Given this list of marker genes NEBL, ADD3, ZBTB20, QKI, AMOTL2, C3orf38, DGKH, KIAA0232, YIPF6, TCF20, SUGP2, ZBTB10, NR2C2, KCTD1, RAB3B, VXN, SGMS1, TYW1B, GRM5, FBXL4, ARL10, PITPNB, ZFHX2, MEGF11, ZNF281, HS1BP3, ZNF570, ARID1B, YWHAB, LMNA, CNTN4, SEC14L1, ZFP36L1, APOOL, TSHZ1, LPP, VPS36, NRXN1, RARRES1, USP49, RBFOX1, MME, SHISA9, ATRN, MINAR1, GLUL, SSH2, MED13L, INO80D, PDS5A, F2R, IVD, BICD2, FCHO2, ZNF470, ARID4A, HBS1L, SMIM9, ERAP1, ZNF704, STEAP2, MEPE, KIF1B, MEF2A, SLC13A1, GTF2A1, PIGK, PIGBOS1, PBX1, MBNL1, ZMAT2, CELF1, CDH12, UNC5D, MAPRE1, GFRA2, LDB3, NRG2, SOS2, MED12L, SCN8A, FRYL, CADM2, CREB5, G3BP1, SBK1, CTBP2, CKAP4, DDHD1, ACVR1C, PHIP, NRXN3, MAST4, MRPL44, F13A1, SGCD, GK5, JADE1, CHRNA3, DUSP10, LAMA4, INHBC, DSTYK, TENT4B, WNK3, GNRHR, OTUD6B, USP13, KLHL24, PCDH7, KLHL31, FUT9, AHDC1, CTH, DNMT3A, ZFP36L2, PTP4A1, POLR3E, MTF1, VPS26A, PKHD1, C1RL, MDM4, SMAD4, IKZF2, TENT5A, CFAP68, TENM1, C2orf88, YIPF5, TNRC6C, RUNX1, FNDC5, NFIB, CAMTA1, RRAGD, NR4A2, PSD3, ETV5, PLAGL2, COL1A1, DNAJB5, ZNF426, PGRMC2, MATR3, CPT1A (carnitine palmitoyltransferase 1A), TASOR2, DCAF5, CACNB4, IGF1, CNTNAP2, FKBP5, PHF21A, VGLL4, ZFHX3, TDRP, FOXP2, IFFO2, ACSL4, THUMPD1, CADM1, TRIM49, GNAQ, ELAVL4, SEMA6A, LIMS1, ZFP1, CAMK2N1, ZNF385D, SBF2, KLHL5, SNRNP27, RYR2, TNRC6B, IFT80, GANC, ITPR1, CDC42EP3, NOL4, USP9X, ZNF678 (zinc finger protein 678), UBASH3B, ADAM10, UQCRHL, NIPBL, AUTS2, TRIM49C, MED29, LYRM7, NEUROD2, RPS6KA5, PCDH17, RUNX1T1, TAB1, CDCA2, DSE, KIF26A, GALNT1, HOXC10, ATP2B3, IL27RA, PBX3, CD2AP, MMP19, PWWP3B, CBLB, EP300, LARP1, FXR1, VCP, REEP1, NALF1, HIPK1, ALOX12B, NEXMIF, TNFSF11, ATF7IP, WDR59, SLC17A6, ZMAT3, ANKS1B, STIM2, SATB1, CIB2, LRRC2, RBMS1, ZNRF1, GABBR2, UNC80, ETV1, PAX6, TAOK1, PALM2AKAP2, MFAP3L, UNC13A, KLF7, ACTN1, ELF1, ZMIZ1, CELF2, RGS17, KLHL32, ETV6, NUP50, RPS6KB1, ZXDA, PDE12, MGLL, CAMK4 (NCBI Gene Id 814), ARL17A, XKR4, OXR1, SLC9A7, LEPROTL1, C6orf47, MBNL3, CSMD2, OSTM1, PIAS4, HAPLN1, ZBTB4, TMEM245, S1PR3 (NCBI Gene Id 414320), PKNOX1, CNN3, TAOK3, NPEPPS (aminopeptidase puromycin sensitive), STAT5B, CLOCK (clock circadian regulator), SLC25A25, SOX4, C14orf28, CHMP2B, LIN54, ADCY2, GLCCI1, TIAL1, RASSF6, POU2F2, NUS1, NEDD1, HIPK2, HCN1, FST, ARHGEF10L, FAT3, OTX1, DLK1, ICAM4, PPP1R12A, CBLIF, CYP20A1, TMEM168, LRIG3, HOXA5, OTUD7B, CASP6, PCLO, APC, XIRP2, PHAX, BPTF, CLNK, PIEZO2, FMR1, SESTD1, KLF17, DAB2IP, TNFRSF9 (TNF receptor superfamily member 9), ELK3, KCNB1, USP6NL, CERS6, AGO3, SUN2, CACNG2, MATN2, U2SURP, TYW1, TCF4, ETS1, MARVELD3, FTHL17, GRIA4 (NCBI Gene Id 2893), VASH2, AKAP10, MAN1A2, TOX, GTF2H5, WDR5B, FHIP2A, DENND1B, MED26, BEAN1, SNTN, ARK2C, METTL2A, BACH2, CBX4, PDZRN4, AS3MT, CAMK1D, UNC13D (unc-13 homolog D), APCDD1, SDAD1, PIK3R1, LRRC4C, TERF2, ACTN4, JARID2, RBMS3, PGR, IKZF5, AMMECR1, HDAC9, STOX2, KANK4 (KN motif and ankyrin repeat domains 4), MINDY2, BEND7, PRR11, PLA2G12A, IGIP, SCAI, NFIC, MAP3K13, RIMS2, EBF1, SBNO1, TSHZ2, IL17RB, PAK3, WNT5A, here is a description of the gene set: Genes predicted to be targets of miRBase v22 microRNA hsa-miR-129-5p in miRDB v6.0 with MirTarget v4 prediction scores > 80 (high confidence targets). Human Gene Set: MIR129_5P from publication Chen Y, Wang X (PMID 31504780) studied in species Homo sapiens